The following is a description of a gene set: The chemical reactions and pathways resulting in the breakdown of glutamate, the anion of 2-aminopentanedioic acid. studied in species Mus musculus Mouse Gene Set: GOBP_GLUTAMATE_CATABOLIC_PROCESS, and this is the list of marker genes: Gad2, Got2, Gad1, Glud1, Adhfe1, Got1